The following is a description of a gene set: Genes up-regulated in C3H10T1/2 cells (mesenchyme multipotent cells) upon their differentiation to brown adipocytes in response to BMP7. from publication Zhang H, Schulz TJ, Espinoza DO, Huang TL, Emanuelli B, Kristiansen K, Tseng YH (PMID 20584981) Both insulin and bone morphogenetic protein (BMP) signaling systems are important for adipocyte differentiation. Analysis of gene expression in BMP7-treated fibroblasts revealed a coordinated change in insulin signaling components by BMP7. To further investigate the cross talk between insulin and BMP signaling systems in brown adipogenesis, we examined the effect of BMP7 in insulin receptor substrate 1 (IRS-1)-deficient brown preadipocytes, which exhibit a severe defect in differentiation. Treatment of these cells with BMP7 for 3 days prior to adipogenic induction restored differentiation and expression of brown adipogenic markers. The high level of adipogenic inhibitor preadipocyte factor 1 (Pref-1) in IRS-1-null cells was markedly reduced by 3 days of BMP7 treatment, and analysis of the 1.3-kb pref-1 promoter revealed 9 putative Smad binding elements (SBEs), suggesting that BMP7 could directly suppress Pref-1 expression, thereby allowing the initiation of the adipogenic program. Using a series of sequential deletion mutants of the pref-1 promoter linked to the luciferase gene and chromatin immunoprecipitation, we demonstrate that the promoter-proximal SBE (-192/-184) was critical in mediating BMP7's suppressive effect on pref-1 transcription. Together, these data suggest cross talk between the insulin and BMP signaling systems by which BMP7 can rescue brown adipogenesis in cells with insulin resistance. species: Mus musculus Human Gene Set: ZHANG_ADIPOGENESIS_BY_BMP7, and this is the list of marker genes: GRB2 (NCBI Gene Id 80715), MYO1C, PIK3C2A, MAP3K5, AKT1, HRAS, SH2B2, IRS1, SGK1, GRB10, AKT2, PIK3R1, MAPK3, GRB14